The following is a description of a gene set: studied in species Homo sapiens Genes whose DNA is hypo-methylated in hepatocellular carcinoma (HCC) compared to normal liver. from publication Acevedo LG, Bieda M, Green R, Farnham PJ (PMID 18413731) Human Gene Set: ACEVEDO_METHYLATED_IN_LIVER_CANCER_DN There is widespread interest in efficient characterization of differences between tumor and normal samples. Here, we show an effective methodology for genome-scale characterization of tumors. Using matched normal and tumor samples from liver cancer patients, as well as non-cancer-related normal liver tissue, we first determined changes in gene expression as monitored on RNA expression arrays. We identified several hundred mRNAs that were consistently changed in the tumor samples. To characterize the mechanisms responsible for creation of the tumor-specific transcriptome, we performed chromatin immunoprecipitation on microarray experiments to assay binding of RNA polymerase II, H3me3K27, and H3me3K9 and DNA methylation in 25,000 promoter regions. These experiments identified changes in active and silenced regions of the genome in the tumor cells. Finally, we used a virtual comparative genomic hybridization method to identify copy number alterations in the tumor samples. Through comparison of RNA polymerase II binding, chromatin structure, DNA methylation, and copy number changes, we suggest that the major contributor to creation of the liver tumor transcriptome was changes in gene copy number., and this is the list of marker genes: TGIF2LY, TMEM132D, CCDC178, FAM27E5, FGFBP1, SMAD9, HOXA6, EPHA8, CLASP2, SOX9, CUEDC2, TSPY10 (NCBI Gene Id 124909093), IKZF1, CCDC33, RASD2, FRMPD1, ZNF595, FAT2, N4BP3, CPXM2, OR5E1P, DPP4, TSPAN5, HOXA4, RGS18, SCRG1, CREBZF, OR7E19P, ARHGAP22, KRTAP3-1, CACNA1B, AMELX, MTMR4, FLT4, FAM13A-AS1, SULT1C4, CCDC136, CSNK1A1L, COL26A1, TRMT12, CSPP1, SLC26A3, FYN (FYN proto-oncogene, Src family tyrosine kinase), ENSG00000301761, CST3 (cystatin C), WWC2, PLG, TSNAX, ANKRD36C, OCEL1, FGD5, DCLK3, HOXB4, MICOS10, GALNT7, FBXO33, LIMCH1, PLAU, ZNF804A, KRTAP2-4, MAB21L1 (NCBI Gene Id 4081), PDE1A, OR7E18P, OR2V2, E2F6, MAGEH1, SLC8A1, POGZ, KRT83, TPRXL, CCDC7, DMRTC1, NUBP1, UBL4B, NPY5R, DUXAP9, FABP6, HS6ST3, NEFM, ARSG (NCBI Gene Id 22901), MATN2, SNX8 (sorting nexin 8), IL2RA, OR4F3, DDX42, MAGEA2, LST1, DYNLT1, ACSS3, FASLG, ADD1, VIPR2, TGIF2LX, KAT6A, APOE, ASZ1, MDH1B, PCDHA11, LACRT, LINGO2, OR6B2, NBPF10, TTI2, VENTXP7, GAGE1, LINC01312, MRGPRX1, IRS1 (NCBI Gene Id 3667), DGKG, KMT2C, SND1 (staphylococcal nuclease and tudor domain containing 1), DPYSL3, NPY2R, ERRFI1, VNN3P, NOX1, HTRA4, HNRNPCL1, WNK2, GAGE12G, TENM2, ZCCHC2, ITIH5, PAMR1, MAP9, NEU4, CDHR2, SERBP1, IK, DMD, CRACD, GKAP1 (G kinase anchoring protein 1), OR1C1 (olfactory receptor family 1 subfamily C member 1), SPIRE1, ADCYAP1R1, EPS8L1, DOCK3 (NCBI Gene Id 1795), PKP4-AS1, TWSG1, PPARD, XAGE1B, ATF7IP, CCSER1, PLSCR2, THSD4, PTPRN2, RBPJL, GLIS1, MAGI3, LINC00955, METTL17, CRYGC, HORMAD2, SPATA18, SUGT1, SLC30A8, CALN1, TTYH2, GRAP2, ENSG00000268460, LSM14A, ANKRD30A, TYW3, MSRA, FAM131B, SLCO5A1, RADIL, MPST, SLC24A4, MED17, KCNAB2, LINC01257, MLLT6, TNS4 (NCBI Gene Id 84951), RSU1, DHX57, TAS2R3, TBC1D3B, CCNJL, NAA40, HEATR5A, ANKRD36B, TBC1D3F, MTX2, BORCS7, MBOAT2, MIER3, BMPR1B, TFF1, NAA11, UXS1, ADAM5, STXBP5 (syntaxin binding protein 5), CCDC196, SULT1A1, FTMT, UCN3, OR13C8, PHYHIP, FOXP1, PRELP, OR6K3, SSX9P, OR7E14P, DENND3, SLC6A18, ABCC8, CIMAP3, OR10Q1, ARMC3, C8orf74, FAM74A4, DPPA3, TTLL10, FCHSD2, CD5, CLNK, PAGE1, IL17A, NBPF12, TBC1D3G, H3P6, ANP32D, MORN2, KRT73, PCDHA13, GDF10, MRGPRX4, TOPAZ1, PPP2R2C, GUCY1A1, TMEM184B, OR7E24, SRI, OR5P2, HOXB6, GTPBP1, INTS12, GLIDR, RAB44, SLC43A1, FAM88B, PDZRN4, VLDLR-AS1, VTI1A, ZNF462, PLCH2, EFHC2, HMGXB3, HBG2, GZMK, KIF1A, SH3PXD2B, SPATA31A7, RBMY1J, SERPINA1, ZBTB8A, FHOD3, MLPH, FCGR1BP, ERF (ETS2 repressor factor), CNGA3 (NCBI Gene Id 44), KIAA1755, NANOGNB, OR6B3, CDH4, HTR2C, FAM47B, LRRK1, NMUR2, HOXA3, AJAP1, ARHGEF10, GK2 (NCBI Gene Id 2712), SLC45A4, GAPDHS, CACNB2, MYT1L, TSPY4, COPA, KIF5C, NAT9, NTNG2, LINC01597, CES1, ST8SIA6-AS1, FKBP5, LINC01517 (long intergenic non-protein coding RNA 1517), MAP2K1, LAMB1, PPP1R12B, OR6V1, GAGE12F, TAC1, PRAMEF4, OR2T35, DIRAS3, DUSP29, SLC17A3, FBXW7, FYB1, JAKMIP1, MYO5A, MOBP (myelin associated oligodendrocyte basic protein), CCDC186, RGS6 (NCBI Gene Id 9628), LYZL4, MYADML, RBMY1B, CRYZ (NCBI Gene Id 1429), SYTL3, OR6N2, ADGRL2, KAZN, ZNF438, POM121L12, SORCS3, SIPA1L2, TRMT10B, LINC02880, MAL2, CLEC12B, KCNA2, PPP2R2A, IGLV4-3, OPTC, MSTO1, CRTAC1, CCDC172, TMCC2, NBPF8, PTPN3, SDK1, ADGRG7, KRT27, OTULINL, POTEE, ADAM11, ADARB2, C1QTNF6, ZNF92, FAM226B, OR6K2, KLF13, IRAK4, ADGRV1, ST6GALNAC3, MYH9, PARGP1, THOC3, LARS2, PDZD8, CIITA, TRPC7, SYTL2, GAPVD1, ABCA11P (NCBI Gene Id 79963), FLG, SCN11A, TDRD6, NBPF4, HMGN5, TRPV6, SPAG11A, MAS1, LYVE1, SPANXB1, MAGEA2B, ZAP70, GCNT7, ERC2-IT1, GLI2, POLR3A, NMNAT3, GRB14 (growth factor receptor bound protein 14), SLC2A1, PRAMEF10, SBSN, PPIAL4A, IQCA1, SMIM19, DEFB1, SLC26A4, F2R, FAXC, FUNDC2P2, MEPE, KCNK2, LINC00305, LINC01168, TREML2, C1QB, CAMTA1, PEBP4, MTHFD2L, TRIM49, RGPD2, PAGE5, TUT7, C10orf55, XCL1, AMBRA1, NME8, FHIP1A, ZMYM4, KIRREL1, ITSN1, FAM27E3, TUBB7P, MEIOB, MTAP, GML, PTPRE, TBC1D3I, CSMD3, SV2B, TSSK1B, PXDNL, ZNF322, STAM, AIFM2, SDR16C5, TDRD9, NGDN, MYO10, HTR3C, RDH13, KRT81, NAV2, TMEM229B, NCOA4, PBOV1, OR4F29, SHROOM3, GP2, NDUFA2, RIPOR2, GRAMD1C, F13A1, TDRD1, ARHGAP24, DTHD1, CA1, OR1I1 (olfactory receptor family 1 subfamily I member 1), SEMA6D, DIRAS2, HOXA5, ITGA8, MCM9, INTS4P1, CFAP144P1, HDGFL1, LYPD6B, ASIC1, CC2D2B, CCDC47, BCRP2, IGKV1-5, DBI, FAM178B, AK5, KLK15, DNAJC3, DAG1, SSX5, ASPN, GATA2, PSG4, LARS1, COL9A1, NAV1, MAPRE2, THEMIS2, OLFM4, XAGE2, FCN2, BPNT2, PYY, NLRP3, AHI1, JOSD1, DHX32, NHLRC3, NUDT9, DISC1, OR2B11 (olfactory receptor family 2 subfamily B member 11), MYH4, OCLN (NCBI Gene Id 4950), MECP2, PRKN, DLGAP2, VPS8, SVOP, MFAP5, SCAMP4, LINC01940, OR4E2, VPS37D, OR2L13, NUGGC (nuclear GTPase, germinal center associated), CLN8, ZNF239, HBG1, PKIA, RBFOX1, SERPINB12, MUC4, ZFY, WDR26, TSPY1, HDAC11, NCK2, RHOA, FGD3, F11-AS1 (F11 antisense RNA 1), HIF3A, UGT2B10, SSX2, GOLGA2, CLDN18, DGKB, OR10C1, MALT1, CSRP3, SLC16A7, KLK1, LINC01657, PXDN, CTBP2, NAGS, PCDHGA2, DMRT3, GOLGA1 (golgin A1), OBP2A, TNF, OR10H2, HERC5, NFYCP2, LPCAT2, TPO, STK32B, TMEM170A, CPLX2, CD1D, TMEM104 (transmembrane protein 104), FAM88D, BIRC8, RPTOR (regulatory associated protein of MTOR complex 1), IGFBPL1, GPR139, SLED1, FAM78A, CRYBG2, ZFPM2, BBS12, HOXB3, ABO, ITFG2, PIWIL1, REXO4, DUOXA1, CDCA7, REXO1L1P, MUCL3, MOB3C, SYNPO2L, TRIM67-AS1, LRRC37A3, TINAG, INSL6, TRPV3, BPIFC, TIAM2 (NCBI Gene Id 340133), SRGN, TKTL2, FMOD, FGF1, GRID1, CPN1, TXNDC16, DOP1A, FILIP1, SERPINA7, SLC26A4-AS1, GALNT14, OR13H1, MSANTD4, TFDP3, ECHDC2, LUZP1, INTS10, GAGE2A, KIF26B, TRIML2, CCDC141, AGPAT4, FASTKD2, GAGE2E, GRIK2, MYO9A, KIDINS220, KALRN, TRIM42, NFASC, SPINK7, PKD2L2, MKRN3, ALOXE3, UBE2D1 (NCBI Gene Id 9335), NBPF22P, ZNF35, GRM8, C1QTNF1 (NCBI Gene Id 81852), MCC, ZBTB34, LARP4B, HKDC1, TRPC3, SCIN, PDZRN3, FAM27C, RBMY1E, IFI44, ARMC5, RASGEF1C, PSD3, GPR12, SCP2, HRNR, EPHA10, BHLHE40 (NCBI Gene Id 8553), OR2Y1 (NCBI Gene Id 79489), LRRC4C, PIPSL, SPANXC, MTNR1A, SBF2, ADAMDEC1, LRPAP1, GTF2A1L, DCHS2, MAGED4B, OBSCN, RBBP8NL, TBC1D12, DEFB105A, UMODL1, H1-7, TANC2, SPINK14, FGF7P6, PTGR2, ADAMTS18, UBE2U, ARHGEF16, FAM197Y2, MYH7, WDR36, DLX1, BCAR1, DEFB106A, TNFRSF4, TST, RNF17, MAFIP (MAFF interacting protein), IGF1R, SSX3, A2ML1, S1PR4, NCKAP1L, CHRM3, GIMAP7, EDA2R, OLFML2B, ANK2 (NCBI Gene Id 4028), AKNA, CSTF2T, FCGR2A, RGS13, RUNX3, CPA1, PRR13, LCN10, H19, GSG1, ODF1 (NCBI Gene Id 4956), PUS7L, TYR, TBC1D4, ADGRF4, ADAM2, NUP35 (NCBI Gene Id 129401), PHEX, SLMAP, KCTD1, WDFY4, SCART1, PRKAG1, FLJ40288 (Putative uncharacterized protein FLJ40288), SPATA31C2, MEST, SLC20A2, FCGR1A, MCPH1-AS1, BTRC, MKNK1, ZXDB, OR10P1, SRF, CNOT2, HCAR2, OR4K5, RAP1A, DYNC2LI1, TMED3 (transmembrane p24 trafficking protein 3), SPAG11B, GSTCD, ZDHHC6, ESD, GALNT8, DDIAS, PASD1 (NCBI Gene Id 139135), IKZF2, DCAF4L2, ASMT, CRYGA, GMCL2 (germ cell-less 2, spermatogenesis associated), WSB2, CD86, ZNF37A, ARAP3, TUBB8, RRH, OTOP1, PDHA2, CNTNAP4, OTUD4, ARHGAP25, H3-3A, NPBWR1, ADGB, CSF2RA, TSPY2, DEFB108B, SPANXA1, RUNX1T1 (RUNX1 partner transcriptional co-repressor 1), RBMY1F, LCN1, ARHGAP6, TENM1, SLC35B4, FOXO3, LTA, SPANXD, GPX1, TET1, CAVIN2, SLC6A19, PTP4A3, SHF, FNDC9, TMEM163, GGA1, OR8K3, VAPA, DENND1A, ST18, CNR1, SLC6A8, NLRX1, ADAMTS13, CAT, OR4F16, ADAT3 (adenosine deaminase tRNA specific 3), OR51I1, NBPF1, RBMY1A1, SSR3, NRAP, SSU72, RGPD8, HRH1, ZNF502, GTSF1, FRMD1, LORICRIN, WDR17, LTB, DEFB107A, URI1, ICOS, SPATA31A3 (SPATA31 subfamily A member 3), MUC17, SPRY1, NPFFR2, TNFRSF8, KCNMB2, FANK1, BICD1, HTR3E, DMKN, SLCO3A1, OR6X1, FUNDC2, SRSF6, TEKT4P2, CASQ2, UNC5A, OR2F2, RBMY1D, VPS13C (vacuolar protein sorting 13 homolog C), LPAR3, CDH13, CCDC80, TRGV9, FFAR2, EGFLAM, OR10H1, FHL5, ASB5, SWI5, PRR23E, HOXD13, DPP6, IL1B, POTEA, TM9SF3, ADGRF5, OR2F1, OR10K1, ACSL1 (acyl-CoA synthetase long chain family member 1), ANK1, CENPF, COL6A5, OR9Q2, ASTN2, SELENOW, UBE2J1, PNLIPRP2, OLAH, CSAG3, CLSTN2, PROSER1, RAPGEF2, C6orf89, TNP1, CLDN1 (NCBI Gene Id 9076), SLC3A1, IGKC, KMT5A, ADAD1, POTEKP, SLCO6A1, COL24A1, ARSF, PEG3, LINC00221, NCSTN, OR4F5, GRWD1, MDM2, ZNF660, PAGE2, COX7B2, ERICH3, DEFB132, KRT86, RNF19A, FAM106A, PRKACG, MATN4, ARSJ, EXPH5, DUOX1, PLXNA4